Given this list of marker genes Cd38, Il5, Fcgr2b, Cd22 (CD22 antigen), Il21, Irs2, Cd300a, Mif, Btk, Pawr, Tnfrsf4, Mzb1, Bmi1, Gpr183, Tlr9, Tnfrsf21, Tfrc, Prlr, Atad5, Tlr4, Ctla4, Ada, Tnfsf13, Btla, Ptprc, Lyn, Ighd, Pkn1, Tsc2, Il2, Casp3, Tirap, Il10, Tnfsf13b, Wnt3a, Cdkn2a, Atm, Cd40, Nckap1l, Cd81, Cd74, Bcl6, Clcf1, Tnfrsf13b, Nfatc2, Rc3h1, Sash3, Cd24a, Cd40lg, Ahr, Ighm (immunoglobulin heavy constant mu), Bst1, Tcf3, Il7, Chrnb2, Mef2c, Il4, Slc39a10, Ticam1, Tnfrsf13c, Il13, Tyrobp, Bcl2, Ephb2, Il3, Card11 (NCBI Gene Id 69728), Cd320, Inpp5d, Pten, Peli1, Cdkn1a, Ikzf3, Vav3, Siglecg, here is a description of the gene set: Mouse Gene Set: GOBP_REGULATION_OF_B_CELL_PROLIFERATION species: Mus musculus Any process that modulates the frequency, rate or extent of B cell proliferation.